The following is a description of a gene set: Human Gene Set: PLASARI_TGFB1_TARGETS_1HR_DN studied in species Mus musculus Transforming growth factor beta (TGF-beta) and platelet-derived growth factor A (PDGFAlpha) play a central role in tissue morphogenesis and repair, but their interplay remain poorly understood. The nuclear factor I C (NFI-C) transcription factor has been implicated in TGF-beta signaling, extracellular matrix deposition, and skin appendage pathologies, but a potential role in skin morphogenesis or healing had not been assessed. To evaluate this possibility, we performed a global gene expression analysis in NFI-C(-/-) and wild-type embryonic primary murine fibroblasts. This indicated that NFI-C acts mostly to repress gene expression in response to TGF-beta1. Misregulated genes were prominently overrepresented by regulators of connective tissue inflammation and repair. In vivo skin healing revealed a faster inflammatory stage and wound closure in NFI-C(-/-) mice. Expression of PDGFA and PDGF-receptor alpha were increased in wounds of NFI-C(-/-) mice, explaining the early recruitment of macrophages and fibroblasts. Differentiation of fibroblasts to contractile myofibroblasts was also elevated, providing a rationale for faster wound closure. Taken together with the role of TGF-beta in myofibroblast differentiation, our results imply a central role of NFI-C in the interplay of the two signaling pathways and in regulation of the progression of tissue regeneration. Genes down-regulated in MEF cells (embryonic fibroblast) upon stimulation with TGFB1 for 1 h. from publication Plasari G, Calabrese A, Dusserre Y, Gronostajski RM, McNair A, Michalik L, Mermod N (PMID 19752192), and this is the list of marker genes: MEIS2, TXNIP, PPP1R3C, NFIB, COL3A1